Given this list of marker genes ALB, CLCN2, RANGRF, SCN5A (sodium voltage-gated channel alpha subunit 5), FHL1, MIR26A1, ADCY10, LRRK2, HCN1, ANK3, GCLC, SCN3B, TBX5, MIR208A, HCN2, KDR, MYOC, TRPM4, CREB1, MIR1-1, GOT1, GPD1L, HSH2D, SCN10A, GCLM, PPP2R3C, SCN1B, SCN2B, MLLT11, PTPN3, CAMK2D, RACK1, HCN4, NPFF, P2RX7, DCN, ABCD1, SLMAP, BCL2, SMAD7, CAV3, BOK, FZD9, NEDD4L, NTSR1, HCN3, TSPO, SRC, CACNA1G, GJA5, PARP1, IFI6, B2M, here is a description of the gene set: species: Homo sapiens Any process that modulates the rate, frequency or extent of membrane depolarization. Membrane depolarization is the process in which membrane potential changes in the depolarizing direction from the resting potential, usually from negative to positive. Human Gene Set: GOBP_REGULATION_OF_MEMBRANE_DEPOLARIZATION